Given this list of marker genes SLC17A5, here is a description of the gene set: SLC17A5 encodes a lysosomal sialic acid transporter, sialin (AST, membrane glycoprotein HP59) which exports sialic acid (N-acetylneuraminic acid, Neu5Ac) derived from the degradation of glycoconjugates from lysosomes. This export is dependent on the proton electrochemical gradient across the lysosomal membrane. SLC17A5 is present in the pathological tumor vasculature of the lung, breast, colon, and ovary, but not in the normal vasculature, suggesting that the protein may be critical to pathological angiogenesis. Sialin is not expressed in a variety of normal tissues, but is significantly expressed in human fetal lung. Defects in SLC17A5 cause Salla disease (SD) and infantile sialic acid storage disorder (ISSD aka N-acetylneuraminic acid storage disease, NSD). These diseases belong to the sialic acid storage diseases (SASDs) and are autosomal recessive neurodegenerative disorders characterised by hypotonia, cerebellar ataxia and mental retardation with patients excreting large amounts of free Neu5Ac in urine. ISSD is a severe infantile form of SASD with a more severe clinical course than SD. Reactome Pathway: Defective SLC17A5 causes Salla disease (SD) and ISSD species: Homo sapiens part of: SLC transporter disorders